The following is a description of a gene set: studied in species Homo sapiens Papilledema Papilledema refers to edema (swelling) of the optic disc secondary to any factor which increases cerebral spinal fluid pressure. Human Gene Set: HP_PAPILLEDEMA, and this is the list of marker genes: PIK3CA, TP53, IDS, NLRP3, BAP1, FREM1, GBA1, CCND1, FGFR1, IL11RA, NF2, SMO, SLC4A2, MMP2, PDGFB, VHL, FAM111A, SOST, BRAF, IFT172, TERT, SUFU, MMP14, CTNNB1, SMARCE1, TRAF7, SMARCB1, AKT1, UQCRFS1, APC